The following is a description of a gene set: studied in species Homo sapiens Human Gene Set: HP_MOTOR_DELAY Motor delay A type of Developmental delay characterized by a delay in acquiring motor skills., and this is the list of marker genes: PPIB, MFN2, PCYT1A, IL1RN, HNRNPK, COL3A1, UBE3B, STAC3, DDC, TSEN15, HDAC4, MECP2, ZNF462, KMT2E, IFT74, MKRN3, ERLIN2, SVBP, TUBG1, DNM1L, GALNS, FKBP14, CDK8, PAFAH1B1, SLC39A8, KCNA1, TMEM63A, VPS41, EP300, MRPS14, HERC2, VPS13B, TUBB4B, LMOD3, NGLY1, RAC1, PIGG, BMP1, GALC, SMC1A, NARS1 (asparaginyl-tRNA synthetase 1), SPOP, EXOSC3, SYNGAP1, GLS, ZFX, SNORD115-1, KPTN, MT-ND1, POLR1C, ODC1, POR, QRICH1, GPC4, MEGF10, NFIB, ADARB1 (adenosine deaminase RNA specific B1), POMT2, GALE (NCBI Gene Id 2582), NBEA, IFT27, DCX, RNF220, CHST3, PSMD12, MPDZ, CHRNE, NDUFS2, VPS4A, IPO8, SCN1A, SFXN4, SCN2A, JAG1, TMEM63C (transmembrane protein 63C), SLC6A3, ZNF408, LYRM4, PTCH1, SEC24D, KCNK4, ATP6AP2, SPTBN4, TRIT1, TSPAN12, ATG7, PIGC, AEBP1, SPART, AARS2, PBX1, CHKB, GUCY2D, LMBRD2, NSRP1, SLC25A12, DARS1, KIF7, GLE1, ELOVL1, NDP, AGTPBP1, CUL3, TSHB, MT-TL1, KDM6A, NPAP1, GJB1, PMP22, PLAG1, ASL (argininosuccinate lyase), CEP295, CDC40, GPC3, TRMT10A, PGM1, CLCNKA, ATPAF2, SOX5, UBE3C, LMNB2, PTRH2, NSD1, PDX1, MYOD1, PACS2, PDE10A, NTNG2 (NCBI Gene Id 84628), TRNT1, MTPAP, CDH11, ATP2B3, DPYD, HECW2, SERPINH1, ALDH18A1, EXOC6B, DDR2, UBE2A, PLEC, WDR45, ITGA7, BICD2, PPP2R5D, RALGAPA1, CTNNA2, SLC31A1, TMEM222, DPH2, RAB3GAP1, CPLX1, TRAPPC6B, TBC1D24, LAMB2, GGPS1, WDR4, MAPK8IP3, BSND, FBN1, FRMD5, RSRC1, MAOA, BMPR1A, HOXA1, COG3, DSE, PPP2CA, TRIP11, CRB1, NAA15, AP4S1, RBPJ, KDM4B, MBOAT7, VRK1, ATL1, PHKG2, CIB2, TNPO3, SLC25A46, ROBO3, INS, IFT140, POLR3B (NCBI Gene Id 55703), INPPL1, UBAP2L, ITCH, MAPRE2, PHOX2A, LARGE1, RPS23, GMPPB, P4HTM, HNRNPC, NTNG1, CEP290, FITM2, STAG2, NAA60, BCAS3, FARSB, YIF1B, MT-ND6, NIPA1, TNFRSF11B, RPGRIP1, FLRT1, TMEM94, TAF8, KDELR2, TMEM147, SPG11, KMT2A, GEMIN5, NOVA2, SLC25A15, SETBP1, PTH1R, CTBP1 (C-terminal binding protein 1), NANS, CSGALNACT1, UBA2, COL2A1, FDXR, HSD17B4 (NCBI Gene Id 3295), DMXL2, SDHAF1, NT5C2, CRAT, GRIA1, NKX3-2, CRELD1, POMGNT1, ZSWIM6 (NCBI Gene Id 57688), RNF170, AP3B2, CLP1, DEAF1, AMFR, RNU4-2, PTPRQ, ACADSB, TRMT1, PCYT2 (phosphate cytidylyltransferase 2, ethanolamine), NFIX, POLR1D, EIF2B4, CANT1, POLR3GL, MYMK, MED13, YARS2, HACD1, ATP5MK, KLHL41, TMEM106B, SET, COQ7, MPV17, DPF2, MMP13, TRRAP, CADM3, ZMYM3, PUS7, MSL3, DOK7, HS2ST1, KIDINS220, CHRND, MYO7A, ASPA, PLXND1, EN1, UQCRFS1, PRX, RRAS2, VARS1, SEPSECS, CLPB, FMR1, PET117, RAD51, FBXL3, HS6ST2, SHMT2, POLR2A, GALNT2, HNMT, CCDC134, TTI1, MYH7, GRIK2, NHLRC2, CYP3A4, RD3, CRPPA, FILIP1, RDH12, SPEG, FGFR3, PRMT7, LBR, GTF2E2, COL5A1, TAFAZZIN, SMC3, FUCA1, NFU1, SMC5, SYNE1, SH3PXD2B, MLC1, CLCN6, KY, TK2, SLC12A2, INPP5E, MT-TH, SPG21, TH, GEMIN4, UGP2, NUDT2, DNAJC21, OPA1, RETREG1, ALMS1, AP1S2, HELLS, FASTKD2, GJC2, NUBPL, TRPV6, ACTA1, PPP1R13L, CUL4B, EFEMP2 (EGF containing fibulin extracellular matrix protein 2), CPT1A, STAT3, ABCA2, TAOK1, NAT8L, ATP5F1A, TNNT1, SLC39A13, LMNB1, CARS1, HADH, PI4K2A (NCBI Gene Id 55361), NKX2-1, ASAH1, HGSNAT, IDH1, PLP1, LIPT2, DARS2, FKTN, NAA10, LRRC32, GNAI1, UPB1, CCNK (NCBI Gene Id 8812), CWC27, SPTLC1, MACF1, GDF6, CUX1, SLC9A7, MORC2, ATP5F1D, RUBCN, SUCLA2, MT-ATP8, DHPS, ATXN7 (ataxin 7), WDR26, LARS2, LMX1B, KCNN2, CTNNB1, CIC, MMAB, MTMR2, SCYL1, GPSM2, YARS1, HECTD4, CIT, PAK1, ACTN2, EGR2, MAN1B1, NFASC, KMT2B, TCF20, TRAF7, NALCN, H19, ALDOA, DPM3, GNB5, YME1L1, KIAA0753, FRA10AC1, KMT2D, PRIM1, DOLK, TMTC3, ZBTB24, MDH2, TNR, SCN8A, NUP54, FUS, CFL2, TUBB4A, CDKL5, SIN3A, AGRN, HEPACAM, TGFB3, FNIP1, TNFRSF11A, ANKRD17, SEMA6B, PTS, RPL10 (NCBI Gene Id 88324), DLG3, NEPRO, NIPBL, CASK, MRAS, SHOC2, MYRF, ZNF592, NEK1, MBTPS1, REPS1, SCN11A, RTL1, SMARCD1, SAMD9, PNPLA2, TRIM2, PCBD1, ARPC4, CSTF2, ROR1 (NCBI Gene Id 4919), ZBTB7A, PGAP1, YY1, ESAM, BRPF1, INPP5K (inositol polyphosphate-5-phosphatase K), CHAT, SOX4, SRD5A3, ABCB7, CHRNB1, PCDH15, DPYSL5, INTS11, ATP6V0A1, NEDD4L (NCBI Gene Id 93998), RARS1, ASXL3, GBF1, MT-CO3, EXOSC2, PURA, DYRK1A, ADNP, GMNN, IVD, APC2, PMPCA, STS, LRP5, SDHA, RAPSN, NDRG1, WDR81, LNPK, SNRPN, EBF3, TIMM50, GABBR1, TRPM3, TENT5A, KIF21A, BCL11B, CHD8, CNKSR2, RAB11B, FZD4, ZMIZ1, AXIN1, ZNF148, TUBB, AIPL1, SLC1A3, ARID2 (AT-rich interaction domain 2), KMT2C, SPARC, KARS1, MBD5, MED27, PUM1, PPFIBP1, CNOT2, ZMYND11, LRAT, TRIP4, PYCR1, CAMK2B, EXT2, VPS35L, ABCC8, TAF4, GPRC5B, MYPN, LONP1, CNOT1, HID1, PHEX, TLK2, DLK1, PCDH19, LRP4, SPR, BCKDK, GDAP1, AGR2, KATNB1, IGF2, PRR12, DLAT, TKFC, CYP2U1, EPRS1, MEG3, COG5, FAR1, EIF4A2, DNAJB4, MAN2C1, PIEZO2 (NCBI Gene Id 63896), AP4B1, COL5A2, RTN2, POMT1, COL1A2, AGK, LCA5, POLR1A, GAA, WDR73, RAP1B, H3-3A, PAX3, DCPS, SATB1, TPM2, SNX14, ACP5, PIGO, KIF14, RSPRY1, PHKA2 (NCBI Gene Id 5256), TAMM41, TMEM107, HMBS, SURF1, DDOST, TNNC2, ELN, SLC1A4, IL6ST, RECQL4, ALS2, SPTAN1, FLG, AHI1, NDUFA1, CHKA, UNC80, XYLT1, MADD, KCNH5, ADA, KLC2, POMK, PWAR1, EXTL3, HYCC1, SH3TC2, GFPT1, GET4, DNASE2, TRIM8, MYL2, CTDP1, ATP6V1A, POLR3K, NIPA2, KAT8, TRMU, PLOD1, COL6A2 (NCBI Gene Id 1292), SNAP25, FBXO11, KDM3B, ALG2, ADCY5, FXR1 (NCBI Gene Id 8087), MED12L, CHRNA1, MT-ATP6, CHST14, MICU1, SMPD1, SLC12A6, CACNA1G, COG4, IFT52, RIPK4, WLS, HPDL, MICOS13, TPM3, NUS1, LTBP4 (latent transforming growth factor beta binding protein 4), ACAT1, LIG1, MUSK, COL6A1, SHANK3, BRAT1, CNOT3, COPB1, SELENOI, GABRA5, WDR62, ARHGEF2, FOXG1, DYM, RYR3, CDK5, NCAPG2, SPTSSA, VPS13D, RALA, ADA2, SCO2, ASCC3, CSNK2A1, GRB10, ACBD6, SMARCA2, FBLN5, SIAH1, CACNA1S (calcium voltage-gated channel subunit alpha1 S), LINGO1, ANAPC7, TMEM38B, SGMS2, GRM1, AUH, TRPV4, LMNA, DPAGT1, ERI1, MYO18B, KDM5C, STX5, EPG5, COL6A3, TUBA1A, ALG12, GALK1, ITPR1, ARID1B, MEF2C, SLC18A2, CDKN1C (NCBI Gene Id 702), TRAPPC10 (NCBI Gene Id 7109), ARCN1, WAC, MARS1, SERPINF1, GABBR2, OTUD7A, SETD1A (SET domain containing 1A, histone lysine methyltransferase), TUBB2B, GAN, USH1C, BPTF, VMA21, SMARCAL1, WWOX, SYT2, AHDC1, VLDLR, AUTS2, ATP10A, B4GALT7, HMGA2, DMD, POGZ, AP4E1, LSS, CSNK2B, AHCY, PRPS1, OPHN1, BAP1, MT-TQ, NCDN, SIK3, LTBP1, GLRB, NAA20, TSEN54, MAP3K20, CDCA7, CRX, CHMP1A, THG1L, CDK13, CHD7, MECR, NEUROD2, TTN, AMN, TTI2 (TELO2 interacting protein 2), FBLN1, USP45, SPTBN2, TSPOAP1, KCNJ11, NSUN6, ZEB2 (zinc finger E-box binding homeobox 2), ATP2A1 (ATPase sarcoplasmic/endoplasmic reticulum Ca2+ transporting 1), BCOR, LAMB1, MCM3AP, TSEN34, MT-ND4, PRKRA, ANTXR1, SNUPN, AMPD2, FTH1, ATG5, GUSB, RORA, ACBD5, TFG, TNRC6B, PSMG2, TSHR, MED13L, NEB, SLC25A42, KAT6A, B3GAT3, MYCN, DYNC1I2, SIM1, RPE65, PSMB1, MPZ, SPATA7, CUBN, GRIN2B, PI4KA, CHD5, TAF1, SLC37A4, IL37, CTCF, GCK, MT-TF, RBL2, COG1, MT-ND5, ROGDI, ERF, MRPS25, DNM2, SARDH, ALG14, OGDH, POMGNT2 (protein O-linked mannose N-acetylglucosaminyltransferase 2 (beta 1,4-)), GARS1, TTC5, CHD3, RAP1GDS1, VAMP1, NRCAM, IQCB1 (NCBI Gene Id 9657), STXBP1, TSEN2, MED12 (NCBI Gene Id 9968), MYH3, SLC18A3, ZBTB11, SPTBN1, ATP5F1E, MESD, PAX7, MINPP1, FBN2, LIAS, KCNJ13, UGDH (NCBI Gene Id 7358), LAMA2, ATP6V0A2, TMEM163, SRCAP, PTEN, NONO, FKRP, TET3, CCBE1, CDH2, SLC6A8, SBF2, UBE3A, EXOSC8, SRRM2, GRIN1, RBM8A, SLC16A2, TULP1, TOR1A, RPS6KA3, SUPT16H, SH2B1, SON, CYP2R1, AGO1, IGF1, RNF125, MT-TW (mitochondrially encoded tRNA-Trp (UGA/G)), NEU1, PDK3, NPHP1, GTPBP2, CPE, SP7, KCNA4, FLNA, MCEE, TRIP12, SLC9A1, IGF1R, NDUFA4, SLC5A7, OTUD6B, KCNC3, RNH1, TUBB3, FGF3, ACTB, ADAMTS2, HUWE1, KDM5B, COASY, IARS2, MT-CO1 (NCBI Gene Id 4512), MT-TN, ADGRL1, MYL1 (myosin light chain 1), FTSJ1, PGM2L1, AK9, RAB3GAP2, ADGRG1, PLAA, FDX2, NFIA, TRIO (trio Rho guanine nucleotide exchange factor), COL12A1, IMPDH1, IQSEC1, MSTO1, SLC25A1, RUSC2, TRAPPC9, DYNC1H1, SDHD, SLC9A6, RNU12, CAMK2A, EXOSC9, BCORL1, KLHL15, COL13A1 (NCBI Gene Id 96775), RFX7, LINS1, MEGF8, CLDN11, MTMR14, ZNF711, FLVCR1, COX10, ZNF407, NEFL, TMCO1, COL25A1, HADHA, RYR1, H4C5, PHKB, PPP2R1A, MYO9A, CLCN7, ZC4H2, SIGMAR1, SELENON (selenoprotein N), CELF2 (NCBI Gene Id 10659), POLD3, MT-TS2, TBR1, BCL11A, COL1A1, CPSF3, STT3A, GHR, CCDC78, FOXP1, NDUFA8, MAGEL2, CREBBP, CHAMP1, ARL13B, DOCK3, ATP6V1E1, AP3B1, KDM6B, MYT1L, CCDC22, OFD1, CDK10, HADHB, FIG4, GFM1, B3GALT6, HARS1 (histidyl-tRNA synthetase 1), SETD5, WASF1, ATP1A1, VDR, KBTBD13, TBK1, RAI1, COQ2, GJA1, MAN2B1, WBP4, PNKP, TANGO2, AGO2, NOTCH3, HNRNPA2B1, ATP1A3, TANC2, PPIL1, GNPTAB, NEXMIF, SPRED1, SLC32A1, PREPL, DHX30, WASHC4, MTM1, SPEN, KAT6B, CLCNKB, MN1, REV3L, EIF3F, CNTNAP2, UBA1, ZNF142, MYF6, MFF, PGAP3, NDUFA12, EHMT1, NMNAT1, KDM1A, SYT1, KPNA3, HPRT1, ASPM (NCBI Gene Id 93990), NDST1, TBCK, DNAJC19, KLHL40, VPS51, BIN1, SNORD116-1, PGAP2, TCF4, GRIA3, PNP, MBTPS2, PRDM13, HK1, NRAS, GBA1, ALDH5A1, SCAF4, GRIA4, PIGA, SRPK3 (NCBI Gene Id 26576), CACNA1C, PLS1, PLPBP, FRMPD4, SCN4A, DAG1, EIF2AK1, COQ4, ABCA12, LARS1, CRBN, CLCN3, KCNQ2, NKX6-2, FGD4, HIVEP2, MT-TE, HIBCH, CYP27B1, FBXW11, MKS1, PWRN1, PAK3, ATP9A (ATPase phospholipid transporting 9A (putative)), SUCLG1, LAMA1, MT-CO2, VPS33A, MLIP, COA8, ORC6, SDHB, MID1, PYGL